The following is a description of a gene set: Human Gene Set: GOBP_POSITIVE_REGULATION_OF_CALCIUM_ION_TRANSPORT_INTO_CYTOSOL species: Homo sapiens Any process that increases the rate of the directed movement of calcium ions into the cytosol of a cell. The cytosol is that part of the cytoplasm that does not contain membranous or particulate subcellular components., and this is the list of marker genes: GRIN1, CAV1, P2RX2, ADCYAP1R1, PLA2G1B, BAX, P2RX4, P2RX5, TRPC3, P2RX3, P2RX7, CD4, ASPH, BAK1